Given this list of marker genes PRKACA, ADCY9, KPNA2, CAMK2A, CAMKK1, ADCY6, ADCY8, PRKACG, NBEA, CALM1, PRKCG, PDE1C, ADCY7, PRKACB, PRKAR1A, PRKAR1B (protein kinase cAMP-dependent type I regulatory subunit beta), CAMK2G, CAMK2D, PRKAR2A, PRKCA, CAMK4, PDE1A, GRK2, ADCY2, PRKX, PDE1B, ADCY3, ADCY4, CAMKK2, ADCY5, PRKAR2B, CREB1, ADCY1, PRKCD, CAMK2B, here is a description of the gene set: part of: Ca-dependent events; DAG and IP3 signaling Calmodulin (CaM) is a small acidic protein that contains four EF-hand motifs, each of which can bind a calcium ion, therefore it can bind up to four calcium ions. The protein has two approximately symmetrical domains, separated by a flexible hinge region. Calmodulin is the prototypical example of the EF-hand family of Ca2+-sensing proteins. Changes in intracellular Ca2+ concentration regulate calmodulin in three distinct ways. First, by directing its subcellular distribution. Second, by promoting association with different target proteins. Third, by directing a variety of conformational states in calmodulin that result in target-specific activation. Calmodulin binds and activates several effector protein (e.g. the CaM-dependent adenylyl cyclases, phosphodiesterases, protein kinases and the protein phosphatase calcineurin). Reactome Pathway: CaM pathway species: Homo sapiens